Given this list of marker genes PMS2P3, ZRANB3, MYD88, RFC1, BTAF1, MCM8, RAD51B, RECQL5, SPO11, SMARCA2, DDX11L8, ERCC3, WRN, RAD17, RUVBL1, CDK7, MLH1, MCM5, TP53, MRE11, ATRX, WRNIP1, RAD51C, DHX9, RFC2, TTF2, FBH1, HFM1, WAPL, HLTF, DNA2, ZGRF1, POLQ, HELB, DMC1, MSH5, CHTF18 (NCBI Gene Id 64722), SMARCA5, MCM7, RUVBL2, TWNK, DHX30, HELQ, XRCC3, CHD1L, IGHMBP2, FANCM, CHD1, SMARCAD1, PMS2P6, RECQL4, NAV2, MSH3, BPTF, MSH2, MCM9, CHTF8, RFC3, DDX11, ERCC6L, UPF1 (UPF1 RNA helicase and ATPase), PIF1, RAD51, RFC5, PMS2, SMARCAL1, RAD54B, RAD54L, MYO18A, RECQL, G3BP1, DDX3X, MCM4, RAD51D, RBBP4, RTEL1, MCM2, SUPV3L1, MLH3, DDX1, CHD2, CHD7, SMARCA4, RAD54L2, MSH4, DDX12P, BLM, DSCC1, PMS2P1, TOP2B, XRCC2, CECR2, RSF1, RAD50, CHD3, XRCC5, SETX, CHD4, XRCC6, MSH6, PMS2P5, ASCC3, MCM6, ATAD5, BRIP1, CHD5, CHD8 (chromodomain helicase DNA binding protein 8), CHD6, ERCC6 (NCBI Gene Id 282965), TOP2A, RFC4, ERCC2, PMS1, DHX36, MCM3, INO80, SMARCA1, here is a description of the gene set: Human Gene Set: GOMF_ATP_DEPENDENT_ACTIVITY_ACTING_ON_DNA species: Homo sapiens Catalytic activity that acts to modify DNA, driven by ATP hydrolysis.